Given this list of marker genes Rbpms, Zfand1, Mcrip1, Ddx19b, Kpna2, Pqbp1, Ssb, Mov10 (Mov10 RISC complex RNA helicase), Rc3h1, Ubap2l, Bpi, Lin28a, Pum1, Tia1, Stau1, Dhx36, Igf2bp1 (insulin-like growth factor 2 mRNA binding protein 1), Kpnb1, Lsm14a, Ybx1, Pum2, Khsrp, Fxr1, Trim21, Eif2s1, Qki, Prkaa2, Vcp, Hipk2, Celf1, Nanos3, Eif4a1, Tial1, Rnf135, G3bp2, Eif4e (NCBI Gene Id 668879), Rbm4, Atxn2, Fxr2, Cirbp, Nufip2, Igf2bp2, Ddx1, Pabpc2, Larp1, Casc3, Ythdf2, Ddx25, Larp4, Caprin1, Fmr1, Prrc2c, Rbfox1, Csde1, Dyrk3, Atxn2l, Grb7, Elavl1, Rc3h2, Igf2bp3, Rock1, C9orf72, Hnrnpk, Ddx19a, Endov, Gigyf2, D1Pas1, Habp4, Stau2, Pabpc6, Ythdf3, Rbpms2 (NCBI Gene Id 71973), Ythdf1, Trim25, Ang, G3bp1, Ddx6, Eif4g1, Ctsg, Eif3b, Rptor, Larp4b (La ribonucleoprotein 4B), Nxf1, Pabpc5, Pabpc1l, Dazap2, Pabpc4 (poly(A) binding protein, cytoplasmic 4), Tardbp, Pkp1, Mbnl1, Zfp36, Znfx1, Ago2, Ogfod1, Pabpc4l, Pabpc1, Mcrip2, Ddx3x, here is a description of the gene set: A dense aggregation in the cytosol composed of proteins and RNAs that appear when the cell is under stress. species: Mus musculus Mouse Gene Set: GOCC_CYTOPLASMIC_STRESS_GRANULE